The following is a description of a gene set: studied in species Mus musculus Mouse Gene Set: chrXA7, and this is the list of marker genes: Mir224, Mtmr1, Mir5132, Gm5793 (NCBI Gene Id 635391), Gm6038, Gm23320, Ccnq-ps1, Mir718, Gm14692, Gm8503, Xlr3a, Srpk3, Ctag2, H2al1r-ps, Gm8401, Gm14727, Gm5397, Naa10, Gm5638, Dusp9, Gm26417, Mpp1, Mir883a, Gm8421 (predicted gene 8421), Magea4, Gabra3, Mir742, Gm15363, Emd, Or7b1-ps1, Vbp1, Gm6812, Mamld1, Idh3g, Magea9-ps, Aff2, Gm23615, Gm14728, Mir201, 1700036O09Rik (NCBI Gene Id 73262), Abcd1, Smim9, Pwwp4d, Gm23280, Gm15063, Gm8312, Gm14687, Atp6ap1, Zfp275, Oat-rs1, Gm16189, Gm8172, Mir463, Gm7155, Cldn34b3 (NCBI Gene Id 238829), Gm14725, Gm14732, Bcap31, n-R5s7, Gm14707, Mir547, Gm16407, Hcfc1, Xlr5a, Mir767, Gm14724, Gm25520, Tex28, Gm6806, Gm14659, Tafazzin, Gm14676, Ctag2l1, Mir741, Gm26125, Gm4910, Gm15362, Mir743, Xlr4e-ps, Slc10a3, Cd99l2, Fam220-ps, Xlr5c, Gm14726 (predicted gene 14726), Mir465, Cetn2, Mir465c-2, Pnck, Pnma5, Gm6881, Ubl4a, Gm14735, L1cam, Gm8501, Xlr4c, Xlr5d-ps, Gm22351 (predicted gene, 22351), Gm15367, Gm6760, Gm14668, Pdzd4, Gm15361, Rpl10, Gm14694, Slitrk4, Slc6a8, Pnma6e, Gm14716, Gm14758, Mir2137 (NCBI Gene Id 100316779), Gm5391, Pwwp4b, Gpr50, Flna, Mir509, Gm1140, Gabre, Gm16441, Bgn, Cldn34d, Gm14701, Mir878, Gm6858, Gm15384, Rpl30-ps10, Gm15065, Trex2 (NCBI Gene Id 24102), Gm14721, Gm6783, Gm14846, Gm8344, Fam50a, Tmem185a, Gm14686, Magea7-ps, Vma21, Gm15364, Fate1, Fmr1nb, Pnma3, Mir880, Gm6039, Haus7, G6pdx, Renbp, Spin2-ps3, Gm14704, Gm22785 (predicted gene, 22785), 4930567H17Rik, Gm5398, Gm8545, Gm23000, Gabrq, Gdi1, Gm5757, Gm8310, Pwwp4c, Spin2-ps4, Rpl3-ps2, Fam3a (FAM3 metabolism regulating signaling molecule A), Rplp1-ps1, Arhgap4, F8a, Xlr4b, Mir883b, Gm8522 (NCBI Gene Id 674892), Dnase1l1, Mir465d, Xlr4d-ps, Xlr3d-ps (NCBI Gene Id 667382), Cldn34b4, Gm8260, Hmgb3, Styx-ps, Gm14730, Gm14712, Avpr2, Gm14722, Dkc1, Rpl7a-ps13, Gm26111, Prrg3, Brcc3, Zfp92, Gm6823, Magea10 (NCBI Gene Id 236852), Mir471, Gm15365, 4930447F04Rik, Cmc4, Gm8692, Tktl1, Xlr3e-ps, 4933436I01Rik, Xlr3b, Rab39b, Gab3, Fundc2, Irak1, Gm14688, Ssr4, F8, Atp2b3, Mecp2, Pasd1, Xlr5b, Gm14695, Mtcp1, Xlr3c, Fmr1, 1700111N16Rik, Mir7091, Gm8617, Gm15379, Gm14681, Eola1, Gm14706, Gm25226, Slitrk2, Opn1mw, Or13ae2 (NCBI Gene Id 258393), Gm14729 (predicted gene 14729), Gm6758, Or7r1, Gm8666 (predicted gene 8666), Mtm1, Ids, Mir881, Gm7153, Mir105, Zfp185, Gm25421 (NCBI Gene Id 115489250), Gm22332, Magea9, 4933407K13Rik, Xlr5e-ps, Gm14710, Mir452, Lage3, Gm8410, Gm26276, Xlr4a, Gm14682, Gm24598, Plxnb3, Cnga2, Mir7092, Gm4989, Ikbkg, Pwwp4a, Gm14667, Mir470, Spin2-ps2, Plxna3, Gm14673, 1700020N15Rik (NCBI Gene Id 75509), Spin2d, Gm6062, Ctag2l2, Pls3, Nsdhl, Gm6897 (NCBI Gene Id 628573), Pwwp4-ps